The following is a description of a gene set: Hypermethylation of the 7-(mono)methylguanosine (m(7)G) cap structure at the 2' position of the guanosine residue to convert a mono-methylated cap to a 2,2,7-trimethylguanosine cap structure. This type of cap modification occurs on small nuclear RNAs (snRNAs) and small nucleolar RNAs (snoRNAs) and is dependent on prior guanine-N7 methylation. Human Gene Set: GOBP_7_METHYLGUANOSINE_CAP_HYPERMETHYLATION studied in species Homo sapiens, and this is the list of marker genes: SNRPB, SNRPD1, SNRPF, SNRPG, SNRPD3, SNRPD2, SNRPE, TGS1